The following is a description of a gene set: A transcription factor complex that acts at a regulatory region of a gene transcribed by RNA polymerase III. studied in species Mus musculus Mouse Gene Set: GOCC_RNA_POLYMERASE_III_TRANSCRIPTION_REGULATOR_COMPLEX, and this is the list of marker genes: Gtf3c5, Gtf3c4, Brf2, Brf1, Gtf3c1, Bdp1, Gtf3c2, Gtf3c3, Gtf3c6